Given this list of marker genes Acvrl1, Nepro, Tgfb2, Ascl1, Itgb1bp1 (integrin beta 1 binding protein 1), Tspan14, Sox2, Enho, Jag2, Kit, Cntn6, Pdcd10, Slc35c2, Nod2, Hes1, Mesp1, Bmp2k, Il6st, Zmiz1, Ccn3, Tspan5, Robo1 (roundabout guidance receptor 1), Gsx2, Trp63, Gdf2, Jag1 (NCBI Gene Id 170642), Wnt1, Stat3, Notch1, Dll4, Hes5, Mfng, Dll1, Poglut1, Rfng, Tm9sf5, Robo2, Fgf10, Reck, Aak1, Src (Rous sarcoma oncogene), Gata5, Yap1, Lfng, Epn2, here is a description of the gene set: Any process that activates or increases the frequency, rate or extent of the Notch signaling pathway. species: Mus musculus Mouse Gene Set: GOBP_POSITIVE_REGULATION_OF_NOTCH_SIGNALING_PATHWAY